Given this list of marker genes LRP8, VEGFA, ATF4, STX11, DDIT4, CEBPG, NCEH1, GRPEL2, SLC7A5, STC2, E2F7, TUBE1, DDX10, MTHFD2, CEBPB, CHAC1, here is a description of the gene set: Genes from the red module which are up-regulated in HAEC cells (primary aortic endothelium) after exposure to the oxidized 1-palmitoyl-2-arachidonyl-sn-3-glycerophosphorylcholine (oxPAPC). studied in species Homo sapiens from publication Gargalovic PS, Imura M, Zhang B, Gharavi NM, Clark MJ, Pagnon J, Yang WP, He A, Truong A, Patel S, Nelson SF, Horvath S, Berliner JA, Kirchgessner TG, Lusis AJ (PMID 16912112) Oxidized phospholipids are thought to promote atherogenesis by stimulating endothelial cells (ECs) to produce inflammatory cytokines, such as IL-8. In studies with mouse models, we previously demonstrated that genetic variation in inflammatory responses of endothelial cells to oxidized lipids contributes importantly to atherosclerosis susceptibility. We now show that similar variations occur in cultured aortic ECs derived from multiple heart transplant donors. These variations were stably maintained between passages and, thus, reflect either genetic or epigenetic regulatory differences. Expression array analysis of aortic EC cultures derived from 12 individuals revealed that >genes were regulated by oxidized phospholipids. We have used the observed variations in the sampled population to construct a gene coexpression network comprised of 15 modules of highly connected genes. We show that several identified modules are significantly enriched in genes for known pathways and confirm a module enriched for unfolded protein response (UPR) genes using siRNA and the UPR inducer tunicamycin. On the basis of the constructed network, we predicted that a gene of unknown function (MGC4504) present in the UPR module is a target for UPR transcriptional activator ATF4. Our data also indicate that IL-8 is present in the UPR module and is regulated, in part, by the UPR. We validate these by using siRNA. In conclusion, we show that interindividual variability can be used to group genes into pathways and predict gene-gene regulatory relationships, thus identifying targets potentially involved in susceptibility to common diseases such as atherosclerosis. Human Gene Set: GARGALOVIC_RESPONSE_TO_OXIDIZED_PHOSPHOLIPIDS_RED_UP